The following is a description of a gene set: The multiplication or reproduction of keratinocytes, resulting in the expansion of a cell population. Keratinocytes are epidermal cells which synthesize keratin and undergo a characteristic change as they move upward from the basal layers of the epidermis to the cornified (horny) layer of the skin. Human Gene Set: GOBP_KERATINOCYTE_PROLIFERATION species: Homo sapiens, and this is the list of marker genes: EPPK1, SNAI2, IFT172, INTU, FGF7, ZEB1, TP63, EFNB2, PRKD1 (protein kinase D1), AREG (amphiregulin), MIR21, IL17A (NCBI Gene Id 94918), EPB41L4B, FAM3C, REG3A, MED1, FERMT1 (FERM domain containing kindlin 1), LRG1, CASK, CDKN1A, PTPRK, REG3G, CRNN, CDH3, PPARD, KLF9 (NCBI Gene Id 687), FGF10, KRT2, KLK8, OVOL2, IFT74, CD109, IRF6, GPR15LG, PTCH1, CDKN2A, MDK, IFT57, FST, VDR, STXBP4, CDH13, KDF1, WNT16, SDR16C5, ZFP36, NOTCH2 (NCBI Gene Id 55574), OVOL1, MIR125B1, ZFP36L1, FGFR2, YAP1, EREG, TGM1 (transglutaminase 1), EXTL3, IFT80, IFT52, SRSF6, BCL11B, NFKBIZ, HAS2, SLURP1, SFN